Given this list of marker genes Zfp961, Traf6, Zfp655, Slc25a10, Ghr, Cbfa2t2, Cyyr1, Gabpb2, Samd4b, Stxbp6, Mpzl2, Tmprss11f, Tnfrsf21, Acsm4, Tbx15, Ago3, Scoc, Ythdf3, Akap11, Zfhx4, Gtf2a1l (general transcription factor IIA, 1-like), Klf4, Dynlt3, Rnf13, Pnisr, Cd2ap, Rps6ka3, Zic3, Vcpip1, Phaf1, Pgap1, Herc3, Lsm6, Rab8b, Ankrd13c, Ubxn7, Rc3h1, Esrrg, Cmtr2, Qsox2, Epha4, Cntln, Rnpc3, Gucy1a2, Loxl3, Tmppe, Ccar1 (cell division cycle and apoptosis regulator 1), Otud4, Msl2 (NCBI Gene Id 77853), Marchf5, Adamts1, Eci3, Syce2, Corin, Acap2, Vps33b, Golph3, Mia3, Tmem196, Tfdp1, Eogt, Adrb2, Med1, E2f5, Epb41l3, Tmem135, Tcaf2, Pnpla8, Pdzrn4, Rasa1, Tmem106b, here is a description of the gene set: Genes predicted to be targets of miRBase v22 microRNA mmu_miR_872_3p in miRDB v6.0 with MirTarget v4 prediction scores > 80 (high confidence targets). Mouse Gene Set: MIR_872_3P studied in species Mus musculus from publication Chen Y, Wang X (PMID 31504780)